The following is a description of a gene set: Human Gene Set: GOMF_FLAVIN_ADENINE_DINUCLEOTIDE_BINDING Binding to FAD, flavin-adenine dinucleotide, the coenzyme or the prosthetic group of various flavoprotein oxidoreductase enzymes, in either the oxidized form, FAD, or the reduced form, FADH2. species: Homo sapiens, and this is the list of marker genes: ACOXL, SDHA, MMACHC, FMO1, ACAD11, FMO4, MTRR, TXNRD1, SQOR, QSOX1, STEAP4, ACAD10, NOS2, STEAP3, ACADSB, IVD, MICAL3, CYBB, NOX4, SQLE, FMO3, POR, PRODH2, DUS4L (dihydrouridine synthase 4 like), ILVBL, KDM1B, FMO5, NQO2, GCDH, KMO, ACAD8, DLD, PRODH, ACAD9, PIPOX, DUS3L (dihydrouridine synthase 3 like), ERO1B, CRY1, AGPS, TXNRD2, TXNRD3 (NCBI Gene Id 93415), PPOX, DHCR24, FOXRED2, ACADM, AOX1, AIFM2, MAOB (NCBI Gene Id 4129), GFER, DPYD, FMO2, ACADS, GSR, LDHD, ACOX3, MAOA, AIFM1, MTHFR (methylenetetrahydrofolate reductase), DUS1L, ERO1A, ACOX2, ACOX1, PCYOX1, DDO, COQ6, NOX5 (NCBI Gene Id 79400), CYB5R3, NOS1, CYB5R2, ETFA, DAO, MTO1, ACADL, KDM1A, D2HGDH, DUS2, XDH, MICAL2, ACADVL, NOS3, CHDH, CYB5R1, CRY2, ETFDH, NDOR1, MICAL1 (NCBI Gene Id 64780)